The following is a description of a gene set: Human Gene Set: GOBP_CELL_ADHESION_INVOLVED_IN_HEART_MORPHOGENESIS studied in species Homo sapiens The attachment of a cell, either to another cell or to an underlying substrate such as the extracellular matrix, via cell adhesion molecules that contributes to the shaping of the heart., and this is the list of marker genes: TGFBR2, CPLANE2, RBPJ, RAC1, TGFB2, NOTCH1, ACVR1, FLRT2, GATA5